Given this list of marker genes WDFY3, METTL8, FAM76A, CITED2, DERL1, HDGF, PLXDC2, TPST1, ITGA6, CADPS2, ITSN1, PDCD4, GCNT1, CBFA2T2, CCNT2, GSE1, WRNIP1 (NCBI Gene Id 56897), PRKAR2B, IFIT2, ZFPM1, ZIK1, SIK3, ABCB4, FGD3, TSPO2, TGFBR3, ST3GAL1, RAB37, ZBTB11, ITGB2, EPB41L5, PLCB4, MARVELD2, STT3B, PTTG1IP, FHL1, VWF, TRIB2, DENND5B, SYTL4, ZMAT3, SLC38A5, SSX2IP, NT5C3A, FBXO9, GPAM, BPGM, NDRG3, NAP1L3, MKNK1, MPL, P2RX1, SMIM13, TRPC6, SCML2, MOB1B, AQP1, ALDH1A1, ZDHHC13, TJP1, MLLT3, GORAB, COL5A1, CA2, PTBP3, OSTM1, CPXM1, KLF11, ABCA5, ENPP4, RHAG, CREBRF, DPY19L3, CD9, PTPN12, COL18A1, PSD3, TCEANC2, OTUB2, TMEM64, STARD4, INTS6L, ZBTB43, CA1, ANKIB1, SAP130, YAF2, AMPD3, PPP1R12A, UTRN, GYPC, DPY19L4, MED12L, NIPA1, ITGB3, AQP9, USP32, UNKL, CYTH3, PRDM15, NCKAP1, FRYL, CCND3, GSTM3, HEMGN, MMRN1, PITPNC1, KEL, BLVRB, RNF125, GSTM1, RANBP6, RABIF, EPDR1, INSR, PIP5K1B, ABRAXAS1, ADCY9, SH3GLB1, SPTA1, CLDN7, PML, MAST4, SPIRE1, GIMAP5, NSD3, PGAP4, SOX6, NXPE2, ATP8A1, ZNF12, ANKRD13C, NTN4, PKP2, MAGED2, NUPR1, RHD, MAP9 (NCBI Gene Id 79884), MARCHF7, GRB10, RIOK3, RFK, TBC1D8B, EPB41, NFIA, MYL11, NDN, NBEA, SESN3, MT2A, SLC25A24, TENT5C, RO60, SNX7, NDNF, ADCY6, BEX4, PER3, KLF1, RDH10, RNF217, RAB40B, PTK2, RCVRN, OSBPL8, HIF1A (hypoxia inducible factor 1 subunit alpha), CMAS, CPEB4, DCAF12L1 (DDB1 and CUL4 associated factor 12 like 1), HK1, CCDC136, SNX25, WDR44, OSBPL3, ALG11, CAVIN1, MYCN, RCOR1, TNIK, EPOR, ZFP36L1, SLC9A6, ZCCHC2, NLK, HYCC1, EXOC6, VAMP5, TBXAS1, HACE1, RAP1B, DNMT3A, PPM1L, PLXNC1, DACH1, MECOM, SH3YL1 (SH3 and SYLF domain containing 1), GPR155, SEPTIN8, GFI1B, GHR, here is a description of the gene set: studied in species Homo sapiens Genes up-regulated in NCAM+ NK cells: SELL bright versus SELL dim. from publication Juelke K, Killig M, Luetke-Eversloh M, Parente E, Gruen J, Morandi B, Ferlazzo G, Thiel A, Schmitt-Knosalla I, Romagnani C (PMID 20505160) Human Natural Killer (NK) cells comprise two main subsets, CD56bright and CD56dim cells, that differ in function, phenotype and tissue localization. To further dissect the heterogeneity of CD56dim cells, we have performed transcriptome analysis and functional ex vivo characterization of human NK cell subsets according to the expression of markers related to differentiation, migration or competence. Here, we show for the first time that the ability to respond to cytokines or to activating receptors is mutually exclusive in almost all NK cells with the exception of CD56dim CD62L+ cells. Indeed, only these cells combine the ability to produce interferon (IFN)-gamma after cytokines and proliferate in vivo during viral infection with the capacity to kill and produce cytokines upon engagement of activating receptors. Therefore, CD56dim CD62L+ cells represent a unique subset of polyfunctional NK cells. Ex vivo analysis of their function, phenotype, telomere length, frequencies during ageing as well as transfer experiments of NK cell subsets into immunodeficient mice suggest that CD56dim CD62L+ cells represent an intermediate stage of NK cell maturation, which after restimulation can accomplish multiple tasks and further develop into terminally differentiated effectors. Human Gene Set: GSE21774_CD56_BRIGHT_VS_DIM_CD62L_POSITIVE_NK_CELL_UP